The following is a description of a gene set: A protein complex that is composed of one alpha subunit and one beta subunit, both of which are members of the integrin superfamily of cell adhesion receptors; the complex spans the plasma membrane and binds to extracellular matrix ligands, cell-surface ligands, and soluble ligands. Human Gene Set: GOCC_INTEGRIN_COMPLEX species: Homo sapiens, and this is the list of marker genes: ITGA6, ITGA7 (NCBI Gene Id 81988), ITGA8, ITGB3, ITGA2B, ITGAE, ITGA4, ITGA5, ITGAD, ITGA2, ITGAX (NCBI Gene Id 3687), ITGB7, EMILIN1, ITGBL1, ITGA1, ITGB4, TSPAN32, ITGB1, ITGB6, ITGB5, ITGA11, ITGAM, ITGA9, ITGAL, ITGB2, LYN, ITGA3, ITGA10, ITGB8, ITGAV